Given this list of marker genes POR, FOXL2, HSD3B2, EIF2B1, CYP11B1, CYP17A1, here is a description of the gene set: Abnormal circulating progesterone level species: Homo sapiens Human Gene Set: HP_ABNORMAL_CIRCULATING_PROGESTERONE_LEVEL